Given this list of marker genes HOXA1, FBXO11, NSMF, CHN1, POLR1A, CEP120, SALL1, ARX, GJA5, COL25A1, ZMIZ1, KCNN2, MN1, MAFB, OPA1, CSPP1, SALL4, ROBO3, UBA2, DNM1L, DCC, CCNQ, MED13, KIAA0586, GJA8, PIEZO2, ACKR3, here is a description of the gene set: Duane anomaly studied in species Homo sapiens Human Gene Set: HP_DUANE_ANOMALY A condition associated with a limitation of the horizontal ocular movement with retraction of the globe and narrowing of the palpebral fissure on adduction